The following is a description of a gene set: Human Gene Set: GOBP_CYTOSOLIC_TRANSPORT studied in species Homo sapiens The directed movement of substances or organelles within the cytosol., and this is the list of marker genes: ARL8B, TRAPPC10, RAB9B, VPS29, VPS52, RAB6C, RAB6B, TRIM27, EPS15, BET1L, WIPI1, DOP1A, WASH6P, SNX6, ERC1, RAB7A (NCBI Gene Id 7879), DENND2A, DOP1B, TBC1D10A, SYT7, VPS13C, LRRK2, SRSF10, HEATR5A, CLN5, SGSM2, RAB6A (NCBI Gene Id 5870), RHOBTB3, RAB14, BAIAP3, SNX1, RCSD1, STX16, STX5, VPS53, VPS26A, DENND5A, VPS35, RIC1, CLN3, SYBU, TBC1D14, KIF1A, SNX8, TANC2, AP2A1, GBF1, SNX12, PRKN, ARL1, VPS26B, TBC1D5, AP4M1, SORT1, TPCN2, GOSR1, WIPF3 (WAS/WASL interacting protein family member 3), SPAG9, ARFRP1, STX10, CLTCL1, RAB41, SNX5, RNF126, SYT4, RUFY1, MON2, TMED9, PHETA1, GCC2, PIKFYVE, TMEM87A, WASHC2C, RAB29, GAK, TBC1D10B, MAP2, GOLT1B, VPS54, CES1, VPS13A, BLTP3B, VTI1B, GGA1, PREPL, WASH3P, SORL1, DCTN1, KIF1B, KIF5A, KIF1C, SNX32, RAB6D, UBE2O, WASHC2A, KIF5B, RGP1, TBC1D23, AP5Z1, RAB9A, PLEKHA3, STX6, PPFIA2, VTI1A, RBSN, LAMP1, AP1S1, AP1G1, KLHL20, PLEKHJ1, SNX3, SNX2, EHD3, EIPR1, RAB4B, VAMP3, CLTC, HEATR5B, ATP9A, LAPTM5, GOLT1A, LMAN1 (lectin, mannose binding 1), SYS1, EVI5, TRIM46, CORO7, ARFIP1, CCDC91, RAB7B, YKT6, PHETA2, WASHC1, VPS51, SLC66A2 (NCBI Gene Id 80148), AP1AR, MAGEL2, ACTR2, VPS50, KIF16B, TBC1D10C (TBC1 domain family member 10C), TMEM87B, USP7, TBC1D17, SURF4, ANKFY1, PIP4K2A